Given this list of marker genes SLC35C1, GGT7, SUCLG2, SULT1A1, MPP1, PLP1, GAPDHS, NDUFA9, NPR1, SLC25A42, GDF15, MAPDA, ALDH1A1, CYP2B6 (cytochrome P450 family 2 subfamily B member 6), FUT10, PFKM, SLC4A4, NME6, HYKK, CLSTN3, KGD4, GPR146, PLAAT3, ATP5F1EP2, SYNJ1, ATP1A2, CARNS1, ADCY7, ACER1, KMO, NMNAT1, MAPK1, GALR2, POFUT2, COQ4, CYP3A4, MYH3, HTD2, EPHX3 (NCBI Gene Id 79852), FGF23, PCK1, OSBPL6, NT5C3A, OGT, SLC52A1 (NCBI Gene Id 55065), HNMT, NOXRED1, AASDH, FH, CAV1, ELOVL5, OCRL, CYP3A5, PRKAG2, DDC, FADS6, PTH1R, ENSG00000293349 (novel transcript), HSD17B1, SLC2A1, MTHFD2, SCP2 (NCBI Gene Id 6342), PIAS4, SERINC3, TPI1, AOAH, GDE1, FMO2, PANK4, SPHK2, SLC27A2, TPH2, ABCC6, FOLR1, ASPDH, APOF, ZFP92, CYP2C8, GMPR, NDUFB10, ADCY3, ATP5MF, APOE, ADA2, SDR16C5, DLST, P2RY6, HPD, FDXR, CTHRC1, DBT, CYP4A22, CYP2A7, HAGH, NEIL2, VKORC1, HSPA1B, PGM2, DAOA (NCBI Gene Id 267012), DERA, ISYNA1, SLC35A2, PTAFR, GPRC6A, RENBP, CYB5R3, DLAT, PDE7B, MVD, PRXL2C, NPPB, VKORC1L1, SIRT2 (NCBI Gene Id 22933), HSD17B8 (NCBI Gene Id 7923), BAAT, NR1H2, SCNN1B, SCAP, MOGAT1, BCO2, ATP5MC1, MLST8, ALKBH7, RBP1, ABCD1, CYP4F3, APOC1, ADCY1, PDXDC1, HSD17B14, SCARB1, MLXIPL, HDC, HADH, AGT, EPHX2, NOS1, LDHB, HSPA8, RDH8, DKK3, MIR210 (NCBI Gene Id 406992), ASPA, ACADL, GCDH, KDM1A, SNX17, SHMT2, ACSS3, MIR107, NDUFS5, CYP27B1, SLC25A15, IPMK, GPAM, HK3, MOXD1, ZBTB7A, MPST, TPST2, LIPE, FGGY, GLB1L2, ATIC, AKR1C2, FGF19, VNN2, DCTD, ENO2, NUDT12, GSTP1, SMPDL3A, B3GLCT, UGT2A1, PDK1, GNAI3, CNP, ATPSCKMT, TNFRSF1A, LCAT (NCBI Gene Id 3931), REXO2, B4GALNT2, INPPL1, SLC16A1, FGFR1, KCNQ1, FDFT1, AIG1, INHBA, ETFBKMT, NANP, NUS1, MMUT, GK5, GTPBP1, TKTL1, COX11, OGDH, LPCAT3, FUOM, G6PD, GATM, NAAA, ADSL, PPM1K, UGT1A10 (NCBI Gene Id 54575), STARD7, HPRT1, ELOVL3, LRP2, SLC2A3, IMPA1, ECH1, NUDT7, FAHD2B, ATP5MGL (NCBI Gene Id 267020), NDUFB8, INS, GMPPB, PPA2, TPK1, CYP27C1, MFN1, NNMT, GLB1L3, PTER, USF1, ABCA1, PLA2G10, FASN, ATP6V0C, INPP4B, NR3C1, FAR1, SPHK1, GLUD1, ADCY8, GPX1, ACAD10 (NCBI Gene Id 80724, acyl-CoA dehydrogenase family member 10), NUDT2, AICDA, TH, NDUFB1, ALDH1A3, PRKAA2, AK1, PAPSS1, SDS, DHRS7B, LTA4H, NAALAD2, PDE4D, LRRK2, CACNB4, ACTN3, CD244, CMAHP, SLC17A3, CFTR, NDUFA7, G6PC3, GPX4, DHFRP1, ADTRP, KBTBD2, ALDOA, FOXO1, CYP24A1, PAPSS2, ACACA, PRKG1, N6AMT1, ENPP1, TECRL, MIR182, RPE65, GFPT1, IDO2, ACOT8 (NCBI Gene Id 10005), DAO, CLN3, CTNS, BCAT2, ACADS, ATP5F1E, PFAS, PFKFB4, LPIN3, TWIST1, AHCYL2, TMSB4X, DHRSX, HKDC1, ATP8B1, VPS9D1, ZMPSTE24, PEX5, HYI, TAT, SRD5A3, DDB1, ABCC9, FGFR4, SLC25A13, PRG3, DHFR2, ILVBL, OSBPL3, PGM3, LDHAL6B, SLC45A2, FCSK, HSPA1A (heat shock protein family A (Hsp70) member 1A), AS3MT, EGR1, SLC37A4, APPL2, PAICS (phosphoribosylaminoimidazole carboxylase and phosphoribosylaminoimidazolesuccinocarboxamide synthase), ARNT, TYMS, AIFM2, NDUFAB1, DIP2A, GNPDA1, MT-ND1, CYP2C9, PC, GBA1, OLAH, ACACB, NTHL1, PTGS1, SDHB, DGUOK (deoxyguanosine kinase), CPT1C, MAP2K1, ERFE, MSRA, ANKRD23 (ankyrin repeat domain 23), D2HGDH, CYP26C1, ENOPH1, NT5E, RFK, GDPGP1, OGDHL, MINPP1, LYPLA2, TREM2, NUDT16, NLRC4, MAPK14 (NCBI Gene Id 1432), NDUFB5, PLPP6, ADK, ENO3, ADSS1, SULT2B1, CYP26B1, CRYL1, NCOR1, ADPGK, NME3, EDN2, QPRT, PRKG2 (protein kinase cGMP-dependent 2), HMGCS1, ALDH18A1 (NCBI Gene Id 9193), PDE5A, SULT1C4, ETFDH, ARV1, SCD5 (stearoyl-CoA desaturase 5), OMA1, AMACR, ADH1A, BGLAP, CLK2, TDO2, ACSF3, GUK1, DAB2, UPP1, PM20D1, GSTO2 (NCBI Gene Id 119391), HSD17B7, GNPAT, CLN8, HIF1A, AKT1, GLYAT (glycine-N-acyltransferase), SLC25A12, ACSM6, ATF3, EP300, LACC1, STOML2, CMPK2, CYP7B1, PTGES3, GALM, GPT, SULT1E1 (NCBI Gene Id 6783), IL4I1, NUDT4, NOX4, DHTKD1, GGT5, PRKAA1, MBTPS1, RRM2B, CTH, NDUFS2, EIF6, TGFB1, AK3, NNT, HPDL, ASAH2, NT5C2, ALOX12B, LONP2, SARM1, MCAT, LGMN, HSD17B4, BMP6, LBR, GPT2 (NCBI Gene Id 84706), NME2P1, KYAT3, GPLD1, INPP5J, DHRS3 (NCBI Gene Id 9249), CRABP2, CYP2S1, CYGB, AZIN2, FMO4, FBP1, PGK2, MIR21, PDHB, NR1D1, GMPPA, HIBCH, ABHD1, ACLY, NUDT11, PNPO, FAAH2, PYCR3, AFMID (arylformamidase), GGT3P, TREX1, CHPT1, ACO1, DCK, NPY1R, PFKFB1, BCKDHB, TPST1, ACOT12, ACSM2B (NCBI Gene Id 348158, acyl-CoA synthetase medium chain family member 2B), CYP3A7, SLC23A1 (NCBI Gene Id 9963), PPP4R3B, INSR (NCBI Gene Id 3643), GIT1, COQ9 (NCBI Gene Id 57017), BRCA1, PDK3, PRKAB2, VCP, STAR, PDXK, AGXT2, GLS, GDPD3, SLC25A25, NME2, ECI1, URAD, SFXN1, PDHX, MTRR, STAT5A, ENSG00000274276, CHST15, PTGS2, PFKL (phosphofructokinase, liver type), MAGI3, NUDT5, FADS3, SYK (spleen associated tyrosine kinase), OSBPL2, NDUFA13, PTGES2, SLC25A21, HK1, PAH, ARG1, ATP5MC3, MTAP, SLC19A1, ALDOC (aldolase, fructose-bisphosphate C), PLA2G4C, MOGAT2, PLOD2, ACSL4, PTPN2, LCMT1, CEBPA, NDUFV1, CARNMT1, ENTPD2, PNLIPRP3, HNF4A, ASMTL, HIBADH, HDAC4, NQO2, AK8 (adenylate kinase 8), ASRGL1, EGLN2, CACNA1H, NUDT15, GHR, ABCB11, RBKS, NAGS, ADIPOR2, CREB1, NR0B1, SULT1A4, BLMH, REST, NDUFB6, HACD1, ANKH, CYP2D6, MAT1A, SIRT4, UGT1A6, LRAT, NPR2, PEX7, PFKFB3, ATP5IF1, ITPKC, AGMO (NCBI Gene Id 442510), GBA2, CYP4F22, PRKAR2B, ALDH1B1, RIDA (reactive intermediate imine deaminase A homolog), BPHL, NDUFA12, NDUFC1, GSTA1, AVPR1B, ABCG2, PHKG2, ACMSD, DCXR, NR1H4, IL1B, PIK3CA, PDE2A, MIF, NUDT9, GGTLC1 (gamma-glutamyltransferase light chain 1), TYRP1, ACSL6, DCT, LMF1, UGT1A1, GLUL, FUT1, KAT2B, ATP6V1A, SIRT7, OLA1, PLPP2, ATP5PB, TP53I3, XDH, UGT1A3, FMO3, ACAD9, CD320, PLA2G4D, SLC27A1, NSDHL, CYP11B1, NR1H3, APOBEC3C, LPIN1, ETFB, ACOT9, FUT5, GCKR, PNPLA4, ACADM, AWAT1, LPCAT2, MTHFD2L, AKR1B1, ERLIN1, DGAT1, GCAT, COMT, AGMAT, ANGPTL3, DPM3, GIMAP7, IDI1, TECR, MT-ND2, FUT8, ALPL, PDE4B, PAQR3, NUDT3, DPEP2, CPT2, ATP6V1B2 (ATPase H+ transporting V1 subunit B2), RBP4, PROX1, PDE4A, MCCC1, FHIT, GRHPR, DMAC2L, GLYCTK, ABHD5, BHMT2, THNSL2, GLUD2, TBPL1, SLC25A19, UCHL1, LDLR, QDPR, OCA2 (NCBI Gene Id 4948), DHDDS, ATP1B1, OTOG, PLA2G15, DEGS1, GPD1, PRPSAP1, PUDP, KCNJ11, ACSS2, DDAH2, ALDH5A1, C1QTNF3, SLC38A1, MPI, OAT, ATP5PO, CYP4B1, PPP1R3E, ACOT7, UPB1, PMAIP1, PNPLA2, ALOX15 (arachidonate 15-lipoxygenase), PANK3, AVPR1A, APOBEC3G, GAD2, HOGA1, PRKN, PGM1, NDUFS8, AKR1D1, GCH1, BMP2, DBI, PLA2G6, HSD17B3, DAGLB, RDH11, GLB1L, COQ2, OSBP, SOAT1, MIR27B, WDR5, GATD1, ELOVL1, SLC34A1, MIOX, FAHD2A, SPTLC1, INSIG1, SEPHS2, MTHFS (methenyltetrahydrofolate synthetase), NFKB1 (NCBI Gene Id 4790), IYD, PGAM1, KHK, SHPK, MTARC2, SNAI1, ALDH2, EPM2AIP1, DPM1, PLEK, SDHD, GPD1L, MBTPS2, ADH1B, PER2, SIK1, MME, MMADHC, DNM1L, BCO1, B4GALT1, PXMP4, SULT1B1, UCK2, SELENOS, SUCLA2, MVK, CTPS1, ATP5MK, HSD17B6, ARL2, RDH13 (retinol dehydrogenase 13), FGF1, ACOT11, SELENON, ENPP3, GGT6, NDUFS7, GLS2, ANTKMT, TNXB, NME9, POR, ENO4, SCD, CRY1, NPC1L1, PSEN1, CMAS, IVD, IP6K3, ATCAY, INPP4A, GLYATL1, ADA, NPC1, DHDH, PPP1R3G, ACBD4, MIR27A, PCBD2, CLCN2, PLAA, GLDC, NDUFA3, FBP2, PLCG2 (phospholipase C gamma 2), SEC14L2, AVP, NDUFA2, ACSL3, HAO2, MAN2A1, UPP2, TALDO1, PTS, LDHD, MPC2, GGT1, GADL1, FUT6, HSD3B7, ALOX12, GGTLC2, SLC6A8, TIGAR, RORA, FLAD1, ABCC10, RTN4IP1, ADCYAP1R1, PPARGC1A, LPIN2, DHCR7, FOXK2, APIP, DPYSL5, STARD4, MAT2B, PDE9A, SUCLG1, UBIAD1, FUCA1, RAB23, FABP2, CLN6, ECHDC3, ALDOB, RETSAT, DCAKD, ACSL5, SIRT1, UEVLD, BOLA3, ST6GAL1 (ST6 beta-galactoside alpha-2,6-sialyltransferase 1), IGF1, ATP2B4, G6PC1, LIPA, MAT2A, BRAT1, MGAT4A, TYSND1, BAD, DHRS4, ASL, TP53 (NCBI Gene Id 7157), ABCA5, CASK, PEX13 (peroxisomal biogenesis factor 13), DPYSL2, CBR4, SLC16A3, ARPP19, ATP5MG, MFSD8, PGK1, PDE8A, PRODH2, IL4, AGXT, CPT1A, ADHFE1, LRP5, GMPR2, MTHFR (methylenetetrahydrofolate reductase), TFAP2B, MACROH2A1, UNG, CMPK1, UXS1, OTC, ALDH6A1, PECR, PHGDH, GMPS, AKR1C3, PCCB, SCLY, OARD1, PLA2G2F, DDIT4, NDUFS3, EBP (EBP cholestenol delta-isomerase), FAR2, CS, SOAT2, NAPRT, EXTL2, CYP8B1, ERRFI1, MYH4, TAFAZZIN, SLC25A16 (NCBI Gene Id 8034), C1QTNF12, TSKU (tsukushi, small leucine rich proteoglycan), PEX2, ATP5F1D, IGFBP4, MBD4, SIRT5, GSTM1, ACSM5, STAT3, PLPP3, AGK, TMEM86B, PMM2, ACP3, STARD3, PARK7, ENTPD4, PTHLH, MAN2C1, PTGES, APOC2, MDH1, ASNSD1 (asparagine synthetase domain containing 1), SPR, DKKL1, FN3K, MORC2, C3, NDUFV3, SDHA, PMM1, IRS2, TTC39B, SLC52A3, ME3, MIR33A, CYP11B2, NMNAT2, P2RX7, DUT, AWAT2, MT-ND5, HMGCS2, LDLRAP1, ACSM1, LDHC, FPGS, SLC2A6, BCKDK, HK2, DHRS7, CYP4F8, CYP4A11, IER3, SORBS1, GNE, FADS1, HPGDS, PEDS1, ACAD8, MIR766, OTOGL, ADCY9, MIR342, PPP1CA, KLHL25, MIR98, P2RY1, DHRS9, IGF2, HSD17B12, KARS1, SLC27A3, KIT, PRKAG1, CES1, SULT1A3, FIGNL1, ACADSB, PLTP, MECP2, PINK1, LEPR, PRODH (NCBI Gene Id 9539), DNAJC30, PNPLA3, SFXN3, PRMT3, GNMT, OSBPL5, TK2, MYH6, GALT, SLC22A12, SERPINA12, AMPD2, ADCK2, DISP3, LDHAL6A, GSTM4, ENPP4, ALOX15B, ACSS1, PPP2CA, VLDLR, RBP2, APOA2, OSBPL1A, HACD3, P4HB, MIR30C1, ACOX2, ADH4, TMEM135, MOGAT3, MAN2A2, FMO1, NME1, SPTSSA, NUDT4B, DCAF5, GALE, SDR9C7, ADH7, DPYS, OSBPL9, SERP1, SLC2A9, COQ8B, MIR204, UGT1A9, SMS, CRYM, ALDH1L1, CARD11 (NCBI Gene Id 84433), GUCA1ANB-GUCA1A, UROC1, CES2, TNF, GNAI1, PTGDR, FAHD1, DECR2, PDXP, SLC27A5, SLC25A17, IGFBP3, LRGUK, ATP5F1B, HADHA, PGAM2, GDA, CHST1, PYCARD, NAMPT, AK2 (NCBI Gene Id 83165), ACBD7, PKLR, AASDHPPT, ABHD14B, CYP4F2, NT5C1A, FPGT, NDUFA5, PNLIPRP2, MTHFD1L, NEIL1, APOL2, LIMA1, GFPT2, FAAH, GHRL, MIR103A1, IMPDH2, PRKAG3, DLD, NR5A2, EFL1, ABCC1, MACROD2, SMUG1, SLC22A11, MT-ND6, CETP, GCK, CLYBL (citramalyl-CoA lyase), PLA2G4F (phospholipase A2 group IVF), ARHGAP11B, MAPKAPK2 (NCBI Gene Id 9261), UCP2 (NCBI Gene Id 7351), PLA2G7, NPC2, SLC25A44, FADS2B, DYRK2, APOA5, NPPC, ANGPTL4, PTGDS, ACOXL, GGTA1, PDE10A, LYPLA1, FKRP, NDUFS1, GUCY1B1, GPER1, ACADVL, TYMP, HSD11B2, SMPD1, NDUFB9, UCKL1, CYP4V2, SLC25A32, AKR1C4, BLOC1S6 (NCBI Gene Id 26258), SNCA, NCOA2, MPO, ALDH8A1, BPNT1, SIRT6, ARG2, NCF1, GOT1, DNPH1, RIMKLA, IDH3G, DCTPP1, GC, HECTD4, NTSR1, UGP2, CPT1B, NUDT17, NOS2, ESD, OXCT1, VNN1, DBH, THEM5, SRC, PAFAH1B1, SARDH, LTC4S, MGST3, KAT2A, GNB3, COASY, HSD17B10, NFE2L1, TRIM63, ACSM4, UGT1A7, RDH5 (NCBI Gene Id 81991), ALDH3B1, IDI2, IDO1, CDA, CPA1, AGTR1, FUCA2, PLA2G1B, AACS, RPE, ATP5PD, KYNU, NAGK, ADSS2, FOXK1, CYP2A13, NPL, APOBR, ATP7A, PGD, RIMKLB (ribosomal modification protein rimK like family member B), PPARA, MMAB, PDE1A (phosphodiesterase 1A), FSHB, RPEL1, THEM4, NDUFA1, QNG1 (Q-nucleotide N-glycosylase 1), RPIA, MCCC2, PCSK9, CYP4F12, AK5, GMDS, SLC35A1, PANK1, THTPA, NDUFB3, CSGALNACT1, PPCDC, ACAT2 (acetyl-CoA acetyltransferase 2), PANK2, NAXE, EHHADH, AQP8 (aquaporin 8), COQ5, NUDT19, ALDH3A2, PON1, ICMT, PDSS2, BTD, ODC1, NOCT, SLC46A1, MT-ND3, NDUFB11, CSAD, UROS, GUCY1A2, HDLBP, PTH, CTPS2, PGP, ATF4, H6PD, PDX1, BDH2, ADIPOR1, SLC23A2, FIS1, NADK, CYP2F1, PNPLA8, RNASEH2B, MGLL, G6PC2, ENTPD5, GSK3A, PPIP5K1, TFF3 (trefoil factor 3), AMT (NCBI Gene Id 275), ADCY5, LIPF, FDX1, GALK1, CUBN, EPHA2, ADCY4, DHODH, SERINC5, MALRD1, MGAT1, PLB1, EPHX1, PNLIPRP1, PRKACA, ATP5ME, SOX9, SLC25A22, PLIN5, FUT2, GPAT4, DPEP1, TST, PARG, DLG2, GCLM (glutamate-cysteine ligase modifier subunit), SNAI2, GLRX, PLA2G4B, ATP6V1B1, CYP4F11, NAXD, PRPSAP2, SRD5A2, ALDH1L2, GPI, NME4, NQO1, CYP2E1, SRR, NUDT18, COQ8A, GSTM2, UAP1 (UDP-N-acetylglucosamine pyrophosphorylase 1), ECHDC2, PGAM4 (phosphoglycerate mutase family member 4), NUDT14, ALOX5, INPP5B, PLCB1, IP6K1, APP (NCBI Gene Id 351), TKT, PARP1, SQLE, NUDT1, XYLB, PKM, HMGCL, MGST2, PDE8B, LHCGR, ACSM3, PDK2, AKR1A1, AHCYL1, PM20D2, PCBD1, CEACAM1, RHOQ, ACO2, FLCN, GUCA1A, NT5C3B, APOA1, ITPK1, ATP5F1C, AK7, IMPDH1, CBS, ITPKB, MIR675 (microRNA 675), ACSBG1, NUDT13, ITPKA, DHFR, FMO5, ENTPD7, PRPS1, FABP5, KPNB1, GGCX, FITM2, MTOR, GSTZ1, ABHD3, EDNRB, ERH, LIAS, SLC5A6, CBR3, RORC, NADK2, SLC25A2, NDUFS4, COQ7, MAN2B2, CYP2C18, BCL2L13, C1QTNF1, ACOX3, ECI2, ME1, SGPP1 (sphingosine-1-phosphate phosphatase 1), APOD, ABHD12, DHCR24, FAM3A, GLYATL2, OXCT2, AK6, SESN2, NLN, MLYCD, PGLS, GGTLC3, GAL3ST3, UGT1A4, HMGB1, GARS1, DGLUCY, GNPDA2, HACD2, CYP2C19, SGPP2, PPARG, SLC27A6, CRAT, DGAT2, DECR1, AK4, DTYMK, BMP5, ART4, CAD, LEP (leptin), PPAT, ERLIN2, CYP2W1, PMVK, FUT9, IFNG, PPIP5K2, NANS, SLC4A1, IDH3A, DPYSL3, INSIG2, GSTO1, FABP3, PRTFDC1, ERO1A, PON3, RPTOR, MBLAC2, PNLIP, ALDH4A1, GUCY1A1, CYP2A6, SLC35B4, NDUFC2, OPA1, RLBP1, LPO, AGPS, PHYH, CBR1 (carbonyl reductase 1), SLC22A13, COQ6, CYP19A1, RDH14, DPYSL4, SHMT1, NCEH1, GCLC, ACAT1, AASS, GUCY2F, PPP4R3A, ASAH1, ITPA, SULT2A1, RAN, PPCS, PRPS2, CD74, APOA4, ME2, TM7SF2, SDHC, SLC19A3, UMPS, RRM1, CEL, GIP, PIBF1 (progesterone immunomodulatory binding factor 1), SLC16A9, GAA, PPP1R3B, ENO1, FBN1, HTR2A, DPYD (dihydropyrimidine dehydrogenase), GAMT, GCHFR, COL6A1, ACOT2, MAN2B1, SORD, TCF7L2, MIR132, CD38, HLCS, SLC52A2, ADCY10, PLPP1, MT-ATP6, MYH7, ASPG, PLPBP, SGPL1, PDHA1, RDH16, MT-ND4 (NCBI Gene Id 4538), SLC4A7, ASNS, THAP4, FAH, TGDS, ACSL1, SPTLC2, PTGIS, ADM, MACROD1, ATP5MJ, NUPR1, CYP2U1, NAT8L, ABHD6, LGSN, HGD, NOS3, MIR548P, L2HGDH, SDHAF3, FTCD, TRIB3, NADSYN1, SLC25A10, MSMO1, PDHA2, PLOD3, TBXAS1, QKI, ECHDC1, SLC1A3, NDUFB7, FUT7, MID1IP1, SAMHD1, BHMT, VDAC1 (voltage dependent anion channel 1), ZNF692, PHKA1, OSBPL7, TJP2, DPM2, LIPC, SLC16A12, MTARC1, BRS3, RDH10, GUCY2D, HAAO, PRPS1L1, ACOT4, ENTPD3, DOLK, NME7, FDX2 (ferredoxin 2), AMPD1, NDUFB2, DGKQ, SLC5A3, DLG1, SCPEP1, SLC39A8, XBP1, ABCA2, ABCG1, APOC3, SLC7A7, PYCR1, MRS2, ENTPD1, UGT2A2, NDUFA8, FUT4, PPARD, CYP11A1, GCG (NCBI Gene Id 2641), DDAH1, GPIHBP1, HADHB, PYCR2, ACAD11, HAL, NR0B2, FDPS, DEGS2, ELOVL2, ACSM2A, JMJD8, RDH12, AMPD3, ATP5PF, UQCC3, MTCL2, CD36, APOB, GFUS, AKR7A2, HMGCLL1, CARMIL1, PDE7A, BCAT1, HPGD, SELENOI, CLPX (NCBI Gene Id 10845), NDP, TKFC, SLC25A11, ADCY2, NOX1, CYP51A1, ADIPOQ, FA2H, NDUFA10, GDPD1, CYP2R1, CRTC2, PDE4C, SLC7A11, OGG1, PLA2G3, MECR, IMPA2 (inositol monophosphatase 2), USP7, ABAT, UCP3, NIT2, PGM2L1, PSAT1, GHSR, UAP1L1, POFUT1, SEPHS1, BPGM, CDO1, ACAA2, HACD4, AADAT, AMDHD2, RRM2, MTHFD1, STAT5B, ACOX1, ALDH1A2, GGT2P, CPS1, ACOT1, SDSL, ABCD3, NUDT10, CAT, TSPO, MMAA, ALDH3B2, SC5D, GAPDH, GK2, TTPA, CYP2J2, C7orf50, TPH1 (tryptophan hydroxylase 1), GART, UGDH, ACAA1, PLA2G4A, LPL, PCK2, UPRT, PNP, ONECUT1, GAD1, LIPG, PRXL2B, NME5, GALK2, CASP1, SP7, SLC19A2, UBR4 (NCBI Gene Id 57525), KYAT1, CYP27A1, DAGLA, IRS1, SPTLC3, NDUFB4, ACSBG2, MST1, TDG, ACER2 (NCBI Gene Id 340485), NMRK2, CYP7A1, COQ3, AMN, INPP5A, LSS, CROT, NT5C, ENTPD8, NDUFA6, EDN1, UCK1, PDSS1, PIPOX, NDUFV2, OAS1, PRKAB1, AKR1B10, MT-ND4L, ABCD4, SLC45A3, LHB, NAIP, CYP26A1, APRT, ECHS1, OXSM, IP6K2, LPGAT1, SLC35A3, TTC36, CBFA2T3, NPPA, PLA2G5, GCSH, PSPH, NT5M, ADCY6, AMDHD1, MTLN, MTCH2, HAO1, NUDT8 (NCBI Gene Id 50602), ALOX5AP, ZBTB20 (zinc finger and BTB domain containing 20), MCEE, RD3, MFSD2A, NDUFS6, NMRK1, ABHD2 (abhydrolase domain containing 2, acylglycerol lipase), HMGCR, PIP4P1 (phosphatidylinositol-4,5-bisphosphate 4-phosphatase 1), MDH1B, PFKFB2, AKR1C1, ACBD5, ASS1, CYP1B1, KDM3A, ACSF2, MDH2, MIR96, MOXD2P, IPPK, SLC17A1, IDH2, SCARF1, CYP4Z1, ABCG4, AUH, MT-ATP8, CH25H, ADI1, FECH, GUCY2C, ACER3, WNT4, GLB1, MMACHC, PDK4, AZIN1, PCCA, ABCD2, UGGT1 (UDP-glucose glycoprotein glucosyltransferase 1), TYR, ADH1C, ELOVL4, MYH8, IDH3B, HACL1, DDO, CYP39A1 (cytochrome P450 family 39 subfamily A member 1), AK9, SLC25A18, PFKP, MTR (5-methyltetrahydrofolate-homocysteine methyltransferase), PPTC7, WDTC1, PID1, SLC38A8, SLC27A4, ELOVL6, ALOXE3, GPD2, PPT2, PNKD, APOL1, GNPNAT1, AKT2, LDHA, LETMD1, ATP5MC2, ETFA, ELOVL7 (NCBI Gene Id 79993), ATP5F1A, ACOT6, SREBF2, GFI1, PTGR2, GK, ADH5, SREBF1, SULT1C3 (sulfotransferase family 1C member 3), CRMP1, NT5C1B, AHCY (adenosylhomocysteinase), BEND3, NMNAT3, HINT1, AKR1B15, CYP46A1, PTGR1, CYP1A1, NDUFA11, TTR, UGGT2, GOT2, SULT1A2, CDADC1, NAPEPLD, GOT1L1, SLC39A14, FADS2, ADH6, PPT1, TK1, MIR185, BCKDHA, CYP1A2, UGT1A8, SPTSSB, RANBP2, IDH1, ST3GAL1, GLYATL1B, PDXDC2P-NPIPB14P, here is a description of the gene set: species: Homo sapiens The chemical reactions and pathways involving small molecules, any low molecular weight, monomeric, non-encoded molecule. Human Gene Set: GOBP_SMALL_MOLECULE_METABOLIC_PROCESS